Given this list of marker genes Apobec3, A1cf, Apobec1, Apobec2, Apobec4, here is a description of the gene set: Mouse Gene Set: REACTOME_MRNA_EDITING_C_TO_U_CONVERSION mRNA Editing: C to U Conversion species: Mus musculus